Given this list of marker genes Lrrk2, Map1lc3b, Map1lc3a (NCBI Gene Id 68411), Ncoa4, Cln3, Pik3c3, Lamp2, Sqstm1, Ftl1 (NCBI Gene Id 14325), Gaa, Lamp1, Irgm1, Plekhm1, Fth1, Plekhm2, here is a description of the gene set: species: Mus musculus Mouse Gene Set: GOCC_AUTOLYSOSOME A type of secondary lysosome in which a primary lysosome has fused with the outer membrane of an autophagosome or amphisome. It is involved in the second step of autophagy in which it degrades contents with acidic lysosomal hydrolases.